Given this list of marker genes TWIST2 (NCBI Gene Id 117581), TCEAL9, LMNTD2, IPP, FAM171B, IBA57, UBOX5, FIRRM, WIPI1, ABRAXAS1, FBXL18, CEND1, BCORL1, CACNA2D4, GSX2, NPR2, RGS6, SIT1, SMARCA5, ZFR2, PMFBP1, TCAF1, CENPH, APOL6, GAPDHS, SHF, ZFPM2, GRM2, EPHX2, PRL, THADA, ADORA3, ACKR4, HBB, FDPS, AP1B1, CCN3, YAP1, UBXN10, TIMP4, PRKG1, KRT2, KCTD9, MMRN2, MEMO1, UBL4A, BTC, CCN6, EPCIP, SYT12, TTLL9, KIF3A, SOX5 (NCBI Gene Id 6660), ESRRB, ACKR2, CLDN5, SNED1, PTPN20, SLC4A1, GPR45, ACAT1, PHACTR4, LLGL1, TMEM169, DHX32, ANGPTL2, FXYD2, CNKSR1, TECR, CCDC3, GPLD1, HSPA4L, SLC1A4, PANK2, ADAM28, COL2A1, CEP128, MYO19, MT2A, SGSM3, FSTL5, CYP8B1, GAL3ST4, ADHFE1, CCL24, GAB1, FEZF1, ESPN, TTC23, FOXA1, FBXO46, APOBEC2, GPR150, UBFD1, BIK, SPAG16, ZC3H3, TUBGCP6, ZNF410, ARL4A, NDC80, RAD54B, C6orf132 (NCBI Gene Id 652183), CHRNB4 (NCBI Gene Id 1143), WIPI2, CD5, KCTD15, BCKDK, PFKM, KRTAP3-1, NECTIN3, PALB2, EPB41L3, SCYL2, SPATA9, BRMS1L, CYP2C18, OR2S2, CCHCR1, IQGAP3, OOEP, LRRN4, GAS1, IL17RC, TNFRSF10A, ALOX15, MESP2 (NCBI Gene Id 145873), GPR61, NKX2-8, ZDBF2, H1-10, NPR1, DGCR8, AQP2, EPHA2, EIF5A2, FANCD2OS, PHETA2, AR, KLF17, JADE1, FBXO34, KCNK4 (NCBI Gene Id 50801), THEM5, UBXN2A, CFAP69, FBF1, ZNF184, SULT1A1, PLCD3, FZD10, HOXA3, CELF6, MAVS, KCNE5, TDP1, PRKCG, C11orf24, SBSPON, NUP85, TENT4A, LSM12, SLC20A1 (NCBI Gene Id 6574), ADGRB1, CYP4F22, MDC1, MTFR1, TMEM102, CHRNA4, TMOD2, CMTM2, TMEM132C, TMEM59L, AFG3L2, SLC16A6, SCLY, GULP1, SLCO1A2, WDR27, CC2D2A, GCHFR, SEBOX, RNF182, NUDCD2, ASAH2, HOXA9, KLHDC7A, IFT57, SALL4, HS3ST3B1, PLCH2, STRC, METTL27, ECT2, SEMA3E, ZSCAN20, RB1, F13B, KIF20B, OMP, here is a description of the gene set: from publication Konuma T, Nakamura S, Miyagi S, Negishi M, Chiba T, Oguro H, Yuan J, Mochizuki-Kashio M, Ichikawa H, Miyoshi H, Vidal M, Iwama A (PMID 21540074) species: Homo sapiens Human Gene Set: GSE27786_NKCELL_VS_ERYTHROBLAST_DN Each fraction of mouse hematopoietic cells was purified by cell sorting from bone marrow of 8-week-old C57BL/6 mice, and its gene expression was analyzed. Genes down-regulated in comparison of NK cells versus erythroblasts.